Given this list of marker genes CCR2, MAPKAP1, TGDS, STARD10, FZD6, RPGR, MOB3B, SLC9A9, KCTD14, NUDT9, ATP5MG, TBCA, FNDC4, TNFRSF1B, PECAM1, MREG, TMEM18, BBS9, EBAG9, CHCHD1, SESN3, RBMS2, NBDY, VPS4A, PIP4K2B, CMIP, GALNT12, RNASEL, RAB4A, NDUFB5, PLEKHA8, PXN, CTBP2, ANXA3, ADAP1, GLUD1, PLD3, MYLIP, BANP, DNAJB4, LPIN1, NIPA2, PTP4A3, ARHGAP25, TMEM14A, BLOC1S5, GRB2, RALB, SERPINB9, MAP4K5, VPS72, AGPAT2, IDI1, PAQR3, GSPT2, IL3RA, TNRC6C, OCRL, FUNDC1, BAG1, SELENON, BPNT2, KIF16B, ACSS2, ACTG1, ITFG1 (NCBI Gene Id 81533), LRP8, THEMIS, SLC16A6, DMAC1, ADD1, CDC42EP3, COMMD10, TRMT2B, C1orf21, MTX2, HS3ST3B1, TBC1D9B, HBEGF, CTBS, MAGOHB, ZYG11B, SEMA4A, ANXA2, VGLL4, TMEM171, C2CD5, MYB, ATP5F1E, BMPR1A, MPP7, HLA-A, ALKBH7, MTHFD2L, IVD, PHLDA1, PLS3, CRMP1, TSG101, SCOC, SPTSSA, NTAQ1, KLHL30, AREG (NCBI Gene Id 727738), SCD, GZMK, GADL1, ABCB9, ZFP64, GRAMD4, ACVR2A, EXT2, ELMO2, B4GALT1, H1-0, LMF1, HEMGN, DNAJC10 (NCBI Gene Id 54431), SLC37A2, MICU1, CD37, KLRG1, SIDT1, ACD, KIAA2013, PBX3, MKNK1, TIRAP, UPF3B, TASL, MYL6, TCTA, TNFRSF12A, SERPINE2, FGFR1OP2, VPS37B (VPS37B subunit of ESCRT-I), CKLF, MGAT2, RMDN2, UQCC3, EIF2AK3, WARS2 (NCBI Gene Id 10352), CDPF1, ASNSD1, JCAD, BMP2K, CHRNA5, OSBPL5, EIF1B, HECTD3, CYRIB, CASD1, AP5M1, NFIL3, ADSS1, ARMC7, NAT9, BSG, NPC1, SLC25A16, FAAP20, HSD17B10, TECR, GALNT1, PTGR3, TRIM21, CORO2A, CETN3, LAMB3, NSF, COTL1, RBM7, SUMF1, GIMAP8, CHIC2, METRNL, PTGER3, DNAJB13 (DnaJ heat shock protein family (Hsp40) member B13, NCBI Gene Id 374407), PEX2, ARSB, B3GNT5, CNIH1, ZC2HC1A, SCARB2, SMOX, NABP1, EPAS1, RHOB (NCBI Gene Id 388), RIT1, TRPV2, MTMR1, UAP1, HERC3, PSEN2, SH2D3C, DNAJC19, TM6SF1, TMX4, EOMES (eomesodermin), here is a description of the gene set: studied in species Homo sapiens Effector cells for adoptive immunotherapy can be generated by in vitro stimulation of naïve or memory subsets of CD8+ T cells. While the characteristics of CD8+ T cell subsets are well defined, the heritable influence of those populations on their effector cell progeny is not well understood. We studied effector cells generated from naïve or central memory CD8+ T cells and found that they retained distinct gene expression signatures and developmental programs. Effector cells derived from central memory cells tended to retain their CD62L+ phenotype, but also to acquire KLRG1, an indicator of cellular senescence. In contrast, the effector cell progeny of naïve cells displayed reduced terminal differentiation, and, following infusion, they displayed greater expansion, cytokine production, and tumor destruction. These data indicate that effector cells retain a gene expression imprint conferred by their naïve or central memory progenitors, and they suggest a strategy for enhancing cancer immunotherapy. Human Gene Set: GSE16522_MEMORY_VS_NAIVE_ANTI_CD3CD28_STIM_CD8_TCELL_UP from publication Hinrichs CS, Borman ZA, Cassard L, Gattinoni L, Spolski R, Yu Z, Sanchez-Perez L, Muranski P, Kern SJ, Logun C, Palmer DC, Ji Y, Reger RN, Leonard WJ, Danner RL, Rosenberg SA, Restifo NP (PMID 19805141) Genes up-regulated in comparison of stimulated memory CD8 T cells from pmel-1 mice versus stimulated naive CD8 T cells from pmel-1 mice.